The following is a description of a gene set: Human Gene Set: PAX3_01 species: Homo sapiens Genes having at least one occurrence of the motif TCGTCACRCTTHM in the regions spanning 4 kb centered on their transcription starting sites. This matches the PAX3 transcription factor binding site V$PAX3_01 (v7.4 TRANSFAC)., and this is the list of marker genes: NOL4L, RTF1, PLCXD2, NOTCH2NLA, CLPTM1, FGF10, MAP1A, CRY1, KCNE4, SRSF6, ZIC1, AP1S1, PHF21B, MYH2, ZCCHC12, STXBP1, FBXO11, CBX8, NOTCH2, YARS1, FAM162A, CACNA1G